The following is a description of a gene set: species: Mus musculus Molecular approaches to understanding the functional circuitry of the nervous system promise new insights into the relationship between genes, brain and behaviour. The cellular diversity of the brain necessitates a cellular resolution approach towards understanding the functional genomics of the nervous system. We describe here an anatomically comprehensive digital atlas containing the expression patterns of approximately genes in the adult mouse brain. Data were generated using automated high-throughput procedures for in situ hybridization and data acquisition, and are publicly accessible online. Newly developed image-based informatics tools allow global genome-scale structural analysis and cross-correlation, as well as identification of regionally enriched genes. Unbiased fine-resolution analysis has identified highly specific cellular markers as well as extensive evidence of cellular heterogeneity not evident in classical neuroanatomical atlases. This highly standardized atlas provides an open, primary data resource for a wide variety of further studies concerning brain organization and function. from publication Lein ES, Hawrylycz MJ, Ao N, Ayres M, Bensinger A, Bernard A, Boe AF, Boguski MS, Brockway KS, Byrnes EJ, Chen L, Chen L, Chen TM, Chin MC, Chong J, Crook BE, Czaplinska A, Dang CN, Datta S, Dee NR, Desaki AL, Desta T, Diep E, Dolbeare TA, Donelan MJ, Dong HW, Dougherty JG, Duncan BJ, Ebbert AJ, Eichele G, Estin LK, Faber C, Facer BA, Fields R, Fischer SR, Fliss TP, Frensley C, Gates SN, Glattfelder KJ, Halverson KR, Hart MR, Hohmann JG, Howell MP, Jeung DP, Johnson RA, Karr PT, Kawal R, Kidney JM, Knapik RH, Kuan CL, Lake JH, Laramee AR, Larsen KD, Lau C, Lemon TA, Liang AJ, Liu Y, Luong LT, Michaels J, Morgan JJ, Morgan RJ, Mortrud MT, Mosqueda NF, Ng LL, Ng R, Orta GJ, Overly CC, Pak TH, Parry SE, Pathak SD, Pearson OC, Puchalski RB, Riley ZL, Rockett HR, Rowland SA, Royall JJ, Ruiz MJ, Sarno NR, Schaffnit K, Shapovalova NV, Sivisay T, Slaughterbeck CR, Smith SC, Smith KA, Smith BI, Sodt AJ, Stewart NN, Stumpf KR, Sunkin SM, Sutram M, Tam A, Teemer CD, Thaller C, Thompson CL, Varnam LR, Visel A, Whitlock RM, Wohnoutka PE, Wolkey CK, Wong VY, Wood M, Yaylaoglu MB, Young RC, Youngstrom BL, Yuan XF, Zhang B, Zwingman TA, Jones AR (PMID 17151600) Mouse Gene Set: LEIN_CHOROID_PLEXUS_MARKERS Genes enriched in choroid plexus cells in the brain identified through correlation-based searches seeded with the choroid plexus cell-type specific gene expression patterns., and this is the list of marker genes: Rbm47, Pcolce, Notch2, Slc26a11, Slc24a5, Ace, Pcolce2, Cfh, Cdh3, Tmem72, Syne2, Slco1c1, Pgpep1, Trpv4, Myo7a, Wfdc2, Tbc1d9, Mxra8 (matrix-remodelling associated 8), Acaa2, Prlr, Odad1, Lbp, Sgms2, Kl, Inmt, Tmprss11a, Perp, Lepr, Csrp2, Nid2, Ctsc, Epcip, Slc6a20a, Ecrg4, F13a1, Ldc1, Tgfbi, Slc39a12, Fhad1, Tcn2, Efs, Kif9, Cfap44, Lgals3bp, Slc4a5, Pbxip1, Ttr, Fxyd1, St6galnac2, Abca4, Acacb, Stra6, Spint2, Folr1, Pltp (phospholipid transfer protein), Mgp, Tmem237, Cpq, Adh1, Acad8, Ephx1, Cldn1, Cldn2, Mroh7, Calml4, F5, Prr32, Rbp1, Hemk1, Fads1, Fancm, Itgb5, Kcne2, Ggh, Rsph9, Gc, Lum, Kdr, Ezr, Sulf1, Fzd4, Atp6v0e, Otx2, Rnaset2a, Vwa3a, Sostdc1, Cab39l, Col8a1, Elovl7, Ccnd3, Klhdc7a, Msx1 (NCBI Gene Id 269644), Dusp22, Steap2, Dnali1, Txnip, Col8a2, Col9a3, Ttc21a, Lrp10, Nek11, Cped1, Nxn, Spata17, Tpsab1